Given this list of marker genes ITPR1, IKBKG, GSDMD, RELA, NFKBIA, FCGR2A, IRF3, NLRX1, IFNB1, IL1B, CHUK, CGAS, REL, IKBKB, NFKB1, NLRP3, STING1, F3, TBK1, IKBKE, NFKBIE (NCBI Gene Id 4794), here is a description of the gene set: STING pathway in Kawasaki-like disease and COVID-19 studied in species Homo sapiens Human Gene Set: WP_STING_PATHWAY_IN_KAWASAKILIKE_DISEASE_AND_COVID19